The following is a description of a gene set: Mouse Gene Set: GOMF_3_5_RNA_HELICASE_ACTIVITY studied in species Mus musculus Unwinding of an RNA helix in the 3' to 5' direction, driven by ATP hydrolysis., and this is the list of marker genes: Supv3l1, Dhx9, Aqr, Dhx40, Dhx38, Ythdc2, Skic2